The following is a description of a gene set: studied in species Mus musculus A multi-component enzymatic machine at the replication fork which mediates DNA replication. Includes DNA primase, one or more DNA polymerases, DNA helicases, and other proteins. Mouse Gene Set: GOCC_REPLISOME, and this is the list of marker genes: Cdc5lrt6, Cdc5lrt8, Cdc5lrt4, Cdc5l, Prim2, Bcas2, Rpa1, Helb, Cdc5lrt1, Cdc5lrt5, Plrg1, Donson, Pold2, Rpa3, E2f6, Prpf19, Smarcal1, Prim1, Rpa2, Tonsl, Cdc5lrt7, Ercc5, Xpa, Pold4, Pola2, Pola1, Pold1, Cdc5lrt9, Cdc5lrt10, Pold3